Given this list of marker genes GNB5, APH1A, SHANK2, NECTIN3, NSG1, SLC6A7, HTR3E, NCSTN, CNTNAP2, UNC13B, PLPPR4, KCNA1, PICK1, GABRG3, GRIK5, CSPG5, SLC6A4, TMEM240, OTOF, GRID2, IQSEC3, GPM6A, CHRNB1, GPR179, SYNE1, HIP1R, CLSTN1 (NCBI Gene Id 22883), SLC30A1, GPR151, ERBB4, COL13A1, NETO2, DGKB, PRRT1, C1QC, CDH10, PTPRS, KCNJ8, ADAM10, NRXN2, NECTIN1, GRM3, CHRM2, ADCY8, ADAM23, ASIC1, GABRA3, STX1A, ADORA1, SYT1, KCNA2, GABRA5, ABHD17B, NEO1, SYNDIG1, IGSF9, CPLX3, AKAP5, TAMALIN, CNR2, CACNG5, GRIA3, CHRNA4, CHRNA10, CHRNA6, ZNRF2, DNAJC6, CDH8, CLTA, GHSR, STRN, SLC5A7, GAD2, EPHA4, EFNB1, GRIA4, CHRM1, LHFPL4, LIN7B, CLSTN3, SYT7, UTRN, GLRA1, GRIK4, GLRA2, NDUFS7, SLC6A9, GRIK2 (NCBI Gene Id 2898), RYK, ITGB3, RIMS2, DLG1, CACNA2D2, CHRM5, CACNG8, MTMR2, CNIH3, AP2M1, P2RY1, LRFN4 (NCBI Gene Id 78999), KCNQ5, ATP2B4, IGSF9B, RGS9, APP, PCDHB13, SYAP1, ANK2, SLC6A11, KCTD16, SLC1A7, PPP1R9B, LRRTM2, CLTB, GRIN2D, VWC2, APBA1, DLG3, PNOC, GSG1L, SLITRK3, ATP2B3, SLC6A6, CHRND, RGS7, RAPSN, SLC16A7, GABRR1, PCDH10, GABRE, CRYAB, LIN7A, PPFIA2, CACNA2D3, GABRG2, NINJ1, SHISA6, PCDH8, NLGN2, CHRNA1, ERC2, SYDE2, NTNG1, FBXO45, HTR3D, CFL1, TMEM108, MKLN1, GRIN3A, SHISA9, GRIP1, RAP2A, AP2B1, MUSK, CHRNE, STX11, CHRM4, NLGN4Y, HTR3B, ATP2B2, CACNG7, DNM2, ITGA3, CHRNG, ITGA5, SHANK3, NLGN3, SARM1, LRRC4B, KCNH1, SEMA4F, HTR5A, GRIN2B, ADGRB3, HCN1, SNAP25, ADAM11, ITGA8, CNR1, NETO1, RALA, RIMS3, CHRNA7, LPAR1, NRCAM, CNTNAP4, LRRC4, PDE2A, CSMD2, KCNB1, IL1RAPL1, ELFN2, GRIN2C, ERBB2, GRIA2, DRD1, SORCS3, CHRNB4, DRD2, ITSN2, CHRNA2, SEMA4C, SNAP91, GNAO1, P2RX1, KCNJ3, OPRK1, SHISA8, IGSF21, DDN, PRR7 (NCBI Gene Id 80758), SLITRK5, PTPRD, GRM1, SLC1A2 (NCBI Gene Id 6506), SRPX2, CNTN5, RIMS1, GPHN, ARC, GLRA3, ANK3, ADRA2A, UNC13A, GRID2IP, DLG4, KCND2, SYP, PCDH17, RAC1, SORCS2, OPRL1, LRRTM4, LRRTM3 (leucine rich repeat transmembrane neuronal 3), FAIM2, GRIN1, ATAD1, AKAP9, SSPN, ABHD17C, PI4K2A, PLXNB1, FGF22, HTR2A, ITGB1, DGKI, ABHD17A, NSG2, FMR1 (NCBI Gene Id 5421), IL31RA, SHANK1, CNTN2, GLRB, ERC1, GRM2, GABRB2, ATP2B1, CHRNB2, FZD3, LRP4, BAIAP2, STX19, DLG2, TRPV1, CADM3, GABRD (NCBI Gene Id 2563), KCNC2, SLC4A8, GABRA4, LRRC4C, KCNJ9, LPAR2, GABRR2 (gamma-aminobutyric acid type A receptor subunit rho2), CADPS2, KCNJ2, OPRD1, LRFN3 (leucine rich repeat and fibronectin type III domain containing 3), GABRQ, CLCN2, ATP6AP2, CRKL, ANP32E, GRM7, EPHA7, GRIN2A, GABRR3, PTPRO, DAG1 (dystroglycan 1), FLRT3, SEMA4D, STX1B, NTNG2, DMD, ZDHHC17, CNTN1, SLC6A3, CACNG3, ENO2, DNAJA3, KCNMA1, SCN10A, PDLIM4, ADORA2A, KCNC1, IGSF8, GPR158, GRIK1, NAPA, ADGRL2, GPER1, ADGRL1, LRFN5, SIGMAR1, SLITRK2, SLC9A5, ADORA3, CACNG2, GABRA6, EPHB2, SYT11, SEMA4B, SCRIB, F2R, CASK, ADAM22, CBLN1, LIN7C (NCBI Gene Id 55327), KCNC3, ABHD6, KCNJ4, GRID1, GRIPAP1, NTRK3, HTR1B, NRXN1, PICALM, CHRNA9, CACNA1C, NRP2 (neuropilin 2), PCDH9, SHISA7, LRP8, ACTN2, RIMS4, CHRNB3 (cholinergic receptor nicotinic beta 3 subunit), UNC13C, CLMP, GRIN3B (NCBI Gene Id 116444), CRHR1, PSEN2, KCND3, RPH3A, RAB3GAP2, ADCY1, DAGLA, FBXO2, GABBR1, STX2, NCAM2, SRGAP2, SLC1A6, CNTN6, CTNNA2, NLGN1, CASR, PRRT2, HTR3C, NLGN4X, ZC4H2, SYNJ1, ABCC8, VANGL2, MAGEE1, CHRNA3, NPTN, PTCH1, LINGO2, CNIH2, TRAPPC4, ASIC2, CACNA2D1, GABBR2, EFNB2, RNF10, NRP1, KCNK1, EFNB3, SLC6A2, ELFN1, RGS7BP, KCNK2, LRFN2, NRXN3, ACP4, NRGN, LRFN1, FXYD6, SYDE1, GRM5, GABRA2, CNKSR2, CHRNA5, GABRB3, PSENEN, NAPEPLD, P2RX6, GABRB1, FARP1, GRIK3, GABRG1, PRKCG, SLITRK1, SLC12A5, CACNG4, KCTD12, ATG9A, C1QA, ANK1, TACR1, DBN1, SHC4, FLRT2, TENM2, GRIA1, DTNBP1, KCND1, DENND1A, STXBP1, CLSTN2, CHRM3, KCTD8 (potassium channel tetramerization domain containing 8), NIPSNAP1, PALM, SLC8A3, TMUB1, ITSN1, NOTCH1, SNCAIP, SUSD4, KCNC4, HTR3A, GABRA1, CTNNB1, DOK7, LRRTM1, DCC, PSEN1, LRRC7, here is a description of the gene set: Human Gene Set: GOCC_SYNAPTIC_MEMBRANE A specialized area of membrane on either the presynaptic or the postsynaptic side of a synapse, the junction between a nerve fiber of one neuron and another neuron or muscle fiber or glial cell. studied in species Homo sapiens